The following is a description of a gene set: Mouse Gene Set: GOBP_POSITIVE_REGULATION_OF_EPIDERMAL_CELL_DIFFERENTIATION Any process that activates or increases the frequency, rate or extent of epidermal cell differentiation. studied in species Mus musculus, and this is the list of marker genes: Foxc1, Etv4, Prkch, Ptch2, Pkp1, Ovol2, Notch1, Ncoa3, Kdf1, Alox8, Nme2, Vdr, Fgf2, Bmp4, Ptch1, Sfrp4, Sfn, Sult2b1, Med1, Macroh2a2, Macroh2a1, Cyp27b1, Atoh1, Numa1